The following is a description of a gene set: Human Gene Set: MULLIGHAN_MLL_SIGNATURE_2_UP The 'MLL signature 2': genes up-regulated in pediatric AML (acute myeloid leukemia) with rearranged MLL compared to the AML cases with intact MLL and NPM1. from publication Mullighan CG, Kennedy A, Zhou X, Radtke I, Phillips LA, Shurtleff SA, Downing JR (PMID 17597811) Somatic mutations in nucleophosmin (NPM1) occur in approximately 35% of adult acute myeloid leukemia (AML). To assess the frequency of NPM1 mutations in pediatric AML, we sequenced NPM1 in the diagnostic blasts from 93 pediatric AML patients. Six cases harbored NPM1 mutations, with each case lacking common cytogenetic abnormalities. To explore the phenotype of the AMLs with NPM1 mutations, gene expression profiles were obtained using Affymetrix U133A microarrays. NPM1 mutations were associated with increased expression of multiple homeobox genes including HOXA9, A10, B2, B6 and MEIS1. As dysregulated homeobox gene expression is also a feature of MLL-rearranged leukemia, the gene expression signatures of NPM1-mutated and MLL-rearranged leukemias were compared. Significant differences were identified between these leukemia subtypes including the expression of different HOX genes, with NPM1-mutated AML showing higher levels of expression of HOXB2, B3, B6 and D4. These results confirm recent reports of perturbed HOX expression in NPM1-mutated adult AML, and provide the first evidence that the NPM1-mutated signature is distinct from MLL-rearranged AML. These findings suggest that mutated NPM1 leads to dysregulated HOX expression via a different mechanism than MLL rearrangement. species: Homo sapiens, and this is the list of marker genes: THTPA, TBL2, HOXA5, RFX2, ABHD17A, DNPH1, IL17RA, ELF3, TFEB, ISOC2, MPPE1 (NCBI Gene Id 65258), TGOLN2, ITGB7, SLC8B1 (NCBI Gene Id 80024), AP1S2, SLC15A2, IGFLR1, LGALS1, TBCD, PITPNA, ADARB1, HOXA10, PECAM1, TGFA, CDC42EP3, CASP1, GRB2, GNA12, OCEL1, PLXNC1, LTB4R, COQ2, PLAUR, SPG21, SIRPA, IKZF1, CES1 (NCBI Gene Id 1067), TOLLIP, BATF, RANGAP1, TREX1, HOXB9, OSBPL1A, LRRC20, EFHD2, ITGAL, CXCR4, SMPD1, EAF2, RIMS1, FAM120A, MLLT10, GLG1, ADCY7 (adenylate cyclase 7), C15orf39, CTBS, MBNL1, LCP1, SLC16A3, L1TD1, RNASE2, EML2, RNF167, NUP210, HEXB, HDAC6, MED8, CIAO1, ABR, ABHD2, SH3GLB2, GSK3B, TRAF3IP3, POLH, SLC1A4, ASPSCR1, RNASE3, TAF1B, RMND5B, BLOC1S1, CAT (catalase), RAC2 (Rac family small GTPase 2), PILRA, RANGRF, RBM47, TRIM38, HCK, GNA14, GAS7, P4HB, KIAA0930, FADD, RFC5, TNPO3, PSD4, MFN2, DPEP2, CD300C, FES, PARL, LILRA1, LILRA2, SNRNP25, SZRD1, RER1, CHD3, LYSET (lysosomal enzyme trafficking factor), PLEC, CNPY3, ARL6IP5, RAB6A, NKIRAS2, NCF1, CBFB, NXPE3, RSPH6A, CYBA (NCBI Gene Id 1535), CD2BP2, SCPEP1, RXRA, AKAP9, FAM53B (NCBI Gene Id 9679), MEIS1 (NCBI Gene Id 4211), TMEM126B, NKG7, SAFB2, KNOP1, CD302, NLRP3, IRAK1, STS, SYNGR2, NRGN, POLD4, GAA, HTR1F, ITGAX, OGG1, NIPBL, ESPL1, HIRIP3, HNRNPUL1, AK2, SMCO4, UPB1, YKT6, SIRPB1, MAZ, MRPL35, KRT10, RRP7A, FRAT2, SLA, ABCA7, UNC119, SPI1, NAGPA, IKBKB, PCYT1A, POLR2J, PLA2G4A, MICAL1, LST1, DDX49, RAB29, SYK, ITGB2, EIF4EBP2, PKM, NDUFB8, SLC31A1 (solute carrier family 31 member 1), ARHGAP45, PPIF, TPP1, SLC36A1, TADA3, ACTR2, OAZ1, NDUFS7, SEC23B, RGS14, ALDH3A2, CEBPG (NCBI Gene Id 1054), TRABD, GIT2, LRFN4, PTMS, SAC3D1, THBS4, TASL, LRP10, PLD3, TOR1AIP1, HIC2, PYCARD, BCAP29, METTL25B, DCPS, LILRB4, DDT, SDF4, ALDH3B1, ATP6V0E1, ARHGAP1, IL6R, IQCE, KLC1, HOXA7, SLC22A18, UGGT1, CTSL, OSBPL8, NSFL1C, ADCY9, PPP1R2, PTAFR, IL1RN, PCNX1, CFDP1, SEL1L3, M6PR, CCR1, SMIM10L1 (NCBI Gene Id 100129361), ISG20L2, AKR7A2, NDUFC1, PMM1, FOSL2, COMMD8, ECI1, RNASE2CP, PLOD1, SLC44A4, TIMM17B, RNASE6, IGFBP7, ABCA8, TRAPPC10, KHNYN, GPS2, BMAL1, HTATIP2, LAMP1, GTSE1, DACH1, ITGA7, MALT1, BMI1, DHRS7B, LNPEP, PUDP, MSRB1 (NCBI Gene Id 51734), RNPEPL1, RPS6KA1, HSPA1A, RBKS, ZNF592 (NCBI Gene Id 9640), MR1, MAP2K2, ARHGEF40, PSEN1, S100A6, SEPHS2, VPS37C, DMAC2, FBXW4, TNFRSF10B, MGST2, PRKCD, PLPBP, SLC25A44, RAB4B, SLC27A3, C1RL, ECHDC2, C11orf21, MFSD1, LAPTM5, GNS, ATG3, MFSD13A, HOXA6, GOLGA8N (NCBI Gene Id 728080), SDHD, PBX3, CLTCL1, HCLS1, PTPN22, HOXA9, ZNF446, ZDHHC13, SIPA1, S100A4, ATXN1, EIF4E2, CAPG, ATP8B4, EXOSC4, ATP6V1D, SIRPAP1, RECK, TIGAR, CLCN7, CEP164, ELMO3, CCL23, SERF2, CEBPA, SFMBT1, CLASP2, COMMD4, CSTA, PRRG4, UPF1, IL10RB, ENSG00000274253, PSMB8, IGF2R, EVI2B, RPL22P22, PTK2B, LAMP2, TRAV13-2, CLN3, PAGR1 (NCBI Gene Id 79447), ELF4, RNF19B, FCGR1A, NUP62, BID, DENND2D, ARHGAP11A, IQGAP1, CXCR2, COX8A, MYO1F, BEST1, TMPO, BEGAIN, ARPC2, MAGEF1, THAP11, AKT2, PLIN3, RASSF4, SRRT, HNRNPU, SNX10, NUP50, GRN (NCBI Gene Id 2896), APOC2, KYNU, KCTD13, APBB1IP, CYTH4, TNFSF13, TDRD7 (tudor domain containing 7), DUSP7, DEXI, FLNA, PIP4K2C, MAPK13, PPT1, MVB12B, LILRB2, ARHGEF3, CTSA, UQCRC1, RRBP1, TRPM4 (NCBI Gene Id 8184), GRK6, TNS3, CCND3, MAPKAPK2, PLXNB2, DDX23, AKR7A3, GLYR1, CAMKK2, FXYD6, NINJ2, FEZ1, ID2, PLEKHB2, EHBP1L1, HOXA4, PI4KB, ALAD, APOBR, STAMBP, ADRB2, FBP1, FZD2, SRGN, LAIR1, CLTB, RASSF7, RASSF2, SLC52A2 (NCBI Gene Id 79581), ARPC4, ZNF318, CAND2 (NCBI Gene Id 23066), RAB3D, TK2, NAGA, TRIM44, KPNA1, CNIH4, LAT2, KRI1, SLC9A6, TNFAIP2, ENO1, FUT7, PTPN9, HIP1, COLGALT1, DNAJC1, SLC17A5, SELPLG